Given this list of marker genes TYMS, MCM7, MCM4, ORC6, ATAD2, FEN1 (NCBI Gene Id 5882), PSMC3IP (NCBI Gene Id 51769), USP1, PCNA, TMEM106C, UBE2T, MCM6 (minichromosome maintenance complex component 6), RNASEH2A, HELLS, CLSPN, PCLAF (NCBI Gene Id 9768), RFC4, RFC2, E2F1, RRM2, MCM5, MCM3, MYBL2, DUT, DNAJC9, CDK1, H4C3, SLBP, MAD2L1, DNMT1, CENPK, CENPU, CHAF1A, CDCA5, GMNN, UHRF1, CDC6, CDCA4, GINS2, CDC45, RAD51AP1, DHFR, MCM2, PKMYT1, HMGB2, ASF1B, TK1, ZWINT, CENPM, RRM1, here is a description of the gene set: Genes upregulated in subsets of cells of a given type within various tumors from publication Gavish A, Tyler M, Greenwald AC, Hoefflin R, Simkin D, Tschernichovsky R, Galili Darnell N, Somech E, Barbolin C, Antman T, Kovarsky D, Barrett T, Gonzalez Castro LN, Halder D, Chanoch-Myers R, Laffy J, Mints M, Wider A, Tal R, Spitzer A, Hara T, Raitses-Gurevich M, Stossel C, Golan T, Tirosh A, Suvà ML, Puram SV, Tirosh I (PMID 37258682) studied in species Homo sapiens Human Gene Set: GAVISH_3CA_MALIGNANT_METAPROGRAM_2_CELL_CYCLE_G1_S In this study, an extensive analysis was conducted to define meta-programs (MPs) capturing intra-tumor heterogeneity across a spectrum of tumor types. The approach utilized non-negative matrix factorization (NMF) to analyze each cell type separately within individual tumor samples. This involved the analysis of malignant cells, macrophages, fibroblasts, endothelial cells, epithelial cells, T-cells, and B-cells. NMF was executed with varying parameter values (K=4, 5, 6, 7, 8, 9), thereby generating 39 programs for each cell type per sample. Each NMF program was summarized by the top genes based on NMF coefficients.\nRobust MPs were then delineated for each cell type using a set of stringent criteria, including recurrence within the same tumor, similarity to programs in other tumors, and non-redundancy within a tumor. Subsequently, these robust NMF programs were clustered (per cell type) based on Jaccard similarity, leading to the identification of MPs associated with each cell type.\nTo enhance the quality of the MPs, a refinement steps were undertaken, involving the removal of MPs suspected of reflecting low-quality data (with an overrepresentation of ribosomal proteins or mitochondrial-encoded genes), single-study inclusion, or similarity to miss-annotated cell types.